Given this list of marker genes Gja5, Eno1, Pln, Tmem38b, Abat, Cald1, Rgs2, Calm3, Chrm2, Myocd, Ccn2, Slc8a3, Sod1, Slc9a1, Slc8a1, Edn1, Stub1, Edn3, Sri, Fkbp1b, Dock5, Calm2, Fgf13, Tbxa2r, Calca, Prok2, Map2k1, Tnnt3, Zc3h12a, Ehd3, Gata4, Arg2, Casq2 (NCBI Gene Id 99894), Zdhhc21, Tmem38a, Cacng1, Chga, Atp1a1, Sumo1, Prkca, Kcnj2, Dsp, Scn5a, Setd3, Prkd1, Dock4, Tnnc2, Tnnc1, Hdac4, Hsp90aa1, Npy2r, Kcna1, Cacna1h, Dmpk (NCBI Gene Id 13400), Adrb1, Smad7, Dbn1, Ormdl3, Ptger3, Ghrl, Pkp2, Rangrf, Ptgs1, Atp2b1, Gper1, Tnni3k, Hcn4, Spx, Anxa6, Npnt, Smtn, Edn2, Cav1, Atp2a1 (NCBI Gene Id 11937), Cacna1c, Chrna3, Irag1, Trpm4, Kcnma1, Ptafr, Jup, Eno1b, Itga2, Cacna1s, Nppa, Calcrl, Pawr, Ace2, Chrm3, Cacnb2 (NCBI Gene Id 99300), P2rx1, Cav3, Flt1, Srf, Rnf207, Arhgap42, Tacr2, Adra1a, Chrnb4, Grcc10, Rem1, Htr7, Kit, Adcy10, Akap6, Akap9, Prkg1, Lck, Myh7, Cacnb1, Adrb2, Adra2c, Adra1b, Atp2a2, Calm1, Ptger4, Dsc2, Tnni3, Atp1a2, Scn4a, Stc1, Ank2, Dlg1, Bin1, Mylk2, Dsg2, Oxtr, P2rx4, Strit1, Actn3, Ryr1, Bmp10, Pde4d, Ucn (NCBI Gene Id 22226), Casq1, Adora1, Rhoa, Ptgs2, Gucy1a1, Atp1b1, Adora2b, Nmu, F2r, Tacr1, Adra2a, Grk2, Oxt, Ada, Sphk1 (NCBI Gene Id 66122), Myl3, Kcnq1, Tnnt1 (troponin T1, skeletal, slow), Fxyd1, Kbtbd13, Tacr3, Agrn, Ghsr, Pde5a, Trpv4, Nr4a1, Myh7b, Scn10a, Nkx2-5, Ctnna3, Dmd, Cttn, Adra2b (adrenergic receptor, alpha 2b), Shc1, Ryr2, Tnnt2, here is a description of the gene set: studied in species Mus musculus Mouse Gene Set: GOBP_REGULATION_OF_MUSCLE_CONTRACTION Any process that modulates the frequency, rate or extent of muscle contraction.